Given this list of marker genes HSH2D, IFIT2, IFNA16, TNFSF10, IFIH1, IFNA1, IFNA14, IFNA21, IRF7, IFNA4, OAS3, LYN, IFNA8, XAF1, CD68, OAS2 (NCBI Gene Id 4939), EIF2AK2, NEXN, SAMD9L, TLR3, OAS1, CD38, CCRL2, NOD2, EPDR1, TNF, IFNB1, RIGI, IFNA2, CXCL11, TCN2, IL15, IFNA7, CCR5, here is a description of the gene set: Genes up-regulated in peripheral blood mononuclear cell 24h vs 0h in adults (18-45) (responders (previously immunized)) after exposure to Live attenuated vaccine TC-83, time point 24H. Comment: initial exposure 2-10 months before PBMCs drawn. significant genes chosen for membership in canonical pathways from publication Erwin-Cohen R, Porter A, Pittman P, Rossi C, Dasilva L (PMID 22617845) Venezuelan equine encephalitis virus (VEEV) is a positive-strand RNA Alphavirus endemic in Central and South America, and the causative agent of fatal encephalitis in humans. In an effort to better understand the mechanisms of infection, including differences between people who produce a neutralizing antibody response to the vaccine and those who do not, we performed whole genome transcriptional analysis in human PBMCs exposed in vitro to the live-attenuated vaccine strain of VEEV, TC-83. We compared the molecular responses in cells from three groups of individuals: naive; previously vaccinated individuals who developed a neutralizing antibody response to the vaccine (responders); and those who did not develop a neutralizing antibody response to the vaccine (nonresponders). Overall, the changes in gene expression were more intense for the naive group after TC-83 challenge and least potent in the nonresponder group. The main canonical pathways revealed the involvement of interferon and interferon-induced pathways, as well as toll-like receptors TLR- and interleukin (IL)-12-related pathways. HLA class II genotype and suppression of transcript expression for TLR2, TLR4 and TLR8 in the nonresponder group may help explain the lack of vaccine response in this study group. Because TL3 and TLR7 transcripts were elevated in all study groups, these factors may be indicators of the infection and not the immunological state of the individuals. Biomarkers were identified that differentiate between the vaccine responder and the vaccine nonresponder groups. The identified biomarkers were contrasted against transcripts that were unique to the naive population alone upon induction with TC-83. Biomarker analysis allowed for the discernment between the naive (innate) responses; the responder (recall) responses; and the nonresponder (alternative) changes to gene transcription that were caused by infection with TC-83. The study also points to the existence of HLA haplotypes that may discriminate between vaccine low- and high-responder phenotypes. Human Gene Set: ERWIN_COHEN_PBMC_TC_83_AGE_18_45YO_RESPONDERS_PREVIOUSLY_IMMUNIZED_24HR_DEG_CANONICAL_PATHWAY_MEMBERS_UP studied in species Homo sapiens